The following is a description of a gene set: Any process that modulates the frequency, rate or extent of the directed movement of sodium ions (Na+) into, out of or within a cell, or between cells, by means of some agent such as a transporter or pore. species: Homo sapiens Human Gene Set: GOBP_REGULATION_OF_SODIUM_ION_TRANSPORT, and this is the list of marker genes: UTRN, WNK3, CAV3, WNK4, AHCYL1, DRD2, DLG1, FXYD5, SLMAP, TESC, RANGRF, YWHAH, MIR24-1, FGF13, NHERF1, PTPN3, SNTA1, CAMK2D, ATP1B2, SERPINE2, FXYD6, MIR192, GPD1L, CNKSR3, ANK3, PRSS8, SCN2B, SCN5A, ATP1B1, ATP2B4, NKAIN4, MLLT6, MIR448, DMPK, FXYD1, PRKCE, AKT1, SCN4B, FXYD6P3, WNK2, NEDD4, AGT, SCN3B, NKAIN1, ATP1B3, FXYD3, ADRB2, CHP1, COMMD1, SIK1, SCN1B, FGF12, NKAIN3, GRP, PKP2, WNK1, NOS3, P2RX7, ACTN4, FXYD4, NKAIN2, NOS1, CNTN1, SPTBN4, NKX2-5, P2RX4, STK39, OSR1 (odd-skipped related transcription factor 1), BPIFA1, FXYD2, DMD, TGFB1 (transforming growth factor beta 1), FXYD7, NEDD4L, PCSK9, ATP1A1, PER1